Given this list of marker genes ITGA4, CD3E, ADAM9, CXCL13, ITGB1, SKAP1, DPP4, WNK1, VCAM1, NPNT, ITGA5, ADA, SWAP70, PIEZO1, PODXL, PLPP3, FERMT3, CCL5, here is a description of the gene set: species: Homo sapiens Human Gene Set: GOBP_CELL_CELL_ADHESION_MEDIATED_BY_INTEGRIN The attachment of one cell to another cell via an integrin, a heterodimeric adhesion receptor formed by the non-covalent association of particular alpha and beta subunits.